Given this list of marker genes Psma2, Psmc1, Psmb4, Psmb6, Psmd7, Cdc6, Orc4, Psma5, Cul1, Psmc5, Psmd12, Psma7, Psmc6, Mcm4, Ccna1, Rps27a, Psma1, Orc1, Psmc2, Psma4, Psmc3, Mcm8, Orc3, Psmc4, Psmd6, Psma3, Ubb, Mcm2, Psmb5, Psmd13, Psmd1, Psmb7, Mcm7, Psma6, Orc5, here is a description of the gene set: Reactome Pathway: Orc1 removal from chromatin part of: Switching of origins to a post-replicative state studied in species Mus musculus electronically inferred by orthology from the curated human pathway This event has been computationally inferred from an event that has been demonstrated in another species.<p>The inference is based on the homology mapping from PANTHER. Briefly, reactions for which all involved PhysicalEntities (in input, output and catalyst) have a mapped orthologue/paralogue (for complexes at least 75% of components must have a mapping) are inferred to the other species.